The following is a description of a gene set: Human Gene Set: GOMF_GLUTAMATE_SODIUM_SYMPORTER_ACTIVITY species: Homo sapiens Enables the transfer of a solute or solutes from one side of a membrane to the other according to the reaction: glutamate(out) + Na+(out) = glutamate(in) + Na+(in)., and this is the list of marker genes: SLC1A6, SLC1A3, SLC1A1, SLC1A2, SLC1A7